The following is a description of a gene set: species: Homo sapiens Porphyromonas gingivalis (P. gingivalis) can trigger an inflammatory condition leading to the destruction of periodontal tissues. However P. gingivalis LPS and its fimbriae (FimA) play different roles compared with the live bacteria in the context of intracellular molecule induction and cytokine secretion. To elucidate whether this difference results from different signaling pathways in host immune response to P. gingivalis, its LPS, or its FimA, we examined gene expression profile of human macrophages exposed to P. gingivalis, its LPS, or its FimA. A comparison of gene expression resulted in the identification of three distinct groups of expressed genes. Furthermore, computer-assisted promoter analysis of a subset of each group of differentially regulated genes revealed four putative transcriptional regulation models that associate with transcription factors NFkappaB, IRF7, and KLF4. Using gene knockout mice and siRNA to silence mouse genes, we showed that both TLR2 and TLR7 are essential for the induction of NFkappaB-containing genes and NFkappaB-IFN-sensitive response element (ISRE) cocontaining genes by either P. gingivalis or its purified components. The gene induction via either TLR2 or TLR7 is dependent on both MyD88 and p38 MAPK. However, the unique induction of IFN-beta by P. gingivalis LPS requires TLR7 and IFNalphabetaR cosignaling, and the induction of ISRE-containing gene is dependent on the activation of IFN-beta autocrine loop. Taken together, these data demonstrate that P. gingivalis and its components induce NFkappaB-containing genes through either TLR2- or TLR7-MyD88-p38 MAPK pathway, while P. gingivalis LPS uniquely induces ISRE-containing genes, which requires IFNalphabetaR signaling involving IRF7, KLF4, and pY701 STAT1. Genes down-regulated in macrophages by P.gingivalis FimA pathogen. from publication Zhou Q, Amar S (PMID 18025224) Human Gene Set: ZHOU_INFLAMMATORY_RESPONSE_FIMA_DN, and this is the list of marker genes: AFF3, SHC3, WDR91, DGKZ, INHBB, SLC27A6, TACSTD2, SERAC1, USP30, ANKRD39, CALHM2, LPAR5, IER5L, DBT, KCNE3, TINAG, ZNF843, EPB41, ASCL1, ZBTB14, FGD4 (FYVE, RhoGEF and PH domain containing 4), VGLL4, ZNF692, SPSB2, NCKIPSD, CHCHD4, NDRG2, KLHL23, ZNF571, LRRC1, SIAE, CDKN1C, ECM2, SMAD1, PDE5A, ATP23, FASTKD1, ZNF785, APCDD1, TRIM32, STN1, SLC16A4, SUSD3, COL19A1, FGD3, USP2, FBXO32, NINL, EFCAB3, SMPDL3B, DNTTIP1, FANCE, RAB11FIP4, ZNF555, PWWP3A, VASH2, DOK1, CNOT8, MIS18BP1, RHOBTB2, PSTPIP1, GEMIN6, VSIR, RABGAP1L, RNF166, ENSG00000258716, VIPAS39, ATG4C, SNX18, CITED2, STYK1, PDE6C, ACACB, SLC29A3, GFOD1, TIMM21, C2orf74, CEBPA, AJUBA, AVPI1, PIMREG, CYTH4, MCHR1, TIGAR, IRF4, FRAT2, MCTP2, NR2F6, TUBAL3, LBHD1, GPR180, RANBP6 (NCBI Gene Id 26953), TMCC1, DOK3, DTWD1, CRBN, PCDHGC5, HTR4, HOXB6, CACNB2, PRIMPOL, DCP1B, ZNF540, ZNF718, DHRS9, TLR1, ACTL6B, MRTFB, RPE, KAT14, YPEL4, CNKSR2, ARHGEF3, TAF3, CHD9, SUFU, GLT8D1, MBP, TTC23L, ZMYM3, C9orf40, RPAP3, WIPF1 (NCBI Gene Id 7456), NHSL1, DNAI1, NVL, FRMD4A, FAM217B, OR2L13, CXCR4, LIFR-AS1, MUC16, XKR6, TMEM177, ACKR4, ABHD10, ARHGEF40, MRPS25, LPAR6, TLE3, INTS10, TLR6, HEATR3, CCDC148, POLM, PTH, MAP4K1, PTPRO, PRPSAP1, LIPT2-AS1, MTIF3, ATG4B, NLRC4, PAGR1, DNM3, AURKA, SETDB2, DNAH5, STEAP1, ARHGAP8, TNNI2, SCN7A, SHPK, SLF2, NDE1 (nudE neurodevelopment protein 1), CLPX, BRAT1 (NCBI Gene Id 221927), IRAG2, NIF3L1, KREMEN1, GEMIN2, MARCHF1, CPNE6, CSMD2, NRXN3, RCBTB2, XPC (NCBI Gene Id 7508), C11orf21, SLC5A8, SPRY2, ORC5, ELAVL3, YAE1, MRPS27, ST3GAL3, OTUB2, NAA16, TRPM3, BOLA1, RASGRP3, ZNF366, OR10H2, MBLAC2, AQP11, ORAI3, DEFB122 (NCBI Gene Id 245935), NFATC3, CCDC85A, C7orf25, GPAM, ENHO, TLR10, ARID4A, TSHZ1, ZBED5, NUDT12, LDAH, GATA2-AS1, THYN1, ZNF605, FAM161A, KIAA1217, PRMT9, SLC20A1, CPS1, AP4B1, HHEX, RPUSD3, AKAP14, CYBC1, ARHGAP12, FGF7, EHD3, ATP5MC3, SLAMF6, MS4A6A, IFFO1, PPFIA4, DGCR2, ALOX12B, RIN2, DPF3, ZC3H14, SCN8A, MAF, MYH10, ANKMY2, KIZ, ZNF962P, LDLRAP1, ZFP3, FPGT, HOXA1, SDC1, ZNF362, DAB2, MTF2, CLEC2B, CA10, BICD1, TSC22D1-AS1, OSGEPL1, CSTF1, CEP85, JMJD1C, GHSR, ARAP3, IFT70B, RAB40B, MLYCD, FAM78A, CD300LB, TENT4B, CEP19, PRICKLE1, ZNF165, LINC00632, RIN3, SGSM2, TNFAIP8L1, SLC25A30, CFAP184, REEP1, ZNF853, TMEM107, ZNF395, CDS1